The following is a description of a gene set: Insulin and insulin-like growth factor-1 (IGF-1) act through highly homologous receptors that engage similar intracellular signaling pathways, yet these hormones serve largely distinct physiological roles in the control of metabolism and growth, respectively. In an attempt to uncover the molecular mechanisms underlying their divergent functions, we compared insulin receptor (IR) and IGF-1 receptor (IGF-1R) regulation of gene expression by microarray analysis, using 3T3-L1 cells expressing either TrkC/IR or TrkC/IGF-1R chimeric receptors to ensure the highly selective activation of each receptor tyrosine kinase. Following stimulation of the chimeric receptors for 4 h, we detected genes to be differentially regulated, of which 10 were up-regulated to a greater extent by the IGF-1R. These included genes involved in adhesion, transcription, transport, and proliferation. The expression of mRNA encoding heparin-binding epidermal growth factor-like growth factor (HB-EGF), a potent mitogen, was markedly increased by IGF-1R but not IR activation. This effect was dependent on MAPK, but not phosphatidylinositol 3-kinase, and did not require an autocrine loop through the epidermal growth factor receptor. HB-EGF mitogenic activity was detectable in the medium of 3T3-L1 preadipocytes expressing activated IGF-1R but not IR, indicating that the transcriptional response is accompanied by a parallel increase in mature HB-EGF protein. The differential abilities of the IR and IGF-1R tyrosine kinases to stimulate the synthesis and release of a growth factor may provide, at least in part, an explanation for the greater role of the IGF-1R in the control of cellular proliferation. Genes similarly down-regulated in 3T3-L1 cells (fibroblasts able to differentiate to adipocytes) upon stimulation of INSR or IGFR1 by NTF3. species: Mus musculus from publication Mulligan C, Rochford J, Denyer G, Stephens R, Yeo G, Freeman T, Siddle K, O'Rahilly S (PMID 12213819) Mouse Gene Set: MULLIGAN_NTF3_SIGNALING_VIA_INSR_AND_IGF1R_DN, and this is the list of marker genes: Cradd, Mdfic, H1f0, Wdr45, Kat2b, Sh3bp5, Epb41l4aos, Hsd17b11, Rab9, Pdk4, Ugcg